The following is a description of a gene set: studied in species Homo sapiens Any of the vesicles of the constitutive secretory pathway, which carry cargo from the endoplasmic reticulum to the Golgi, between Golgi cisternae, from the Golgi to the ER (retrograde transport) or to destinations within or outside the cell. Human Gene Set: GOCC_TRANSPORT_VESICLE, and this is the list of marker genes: SYPL2, PICALM, SEC16B (SEC16 homolog B, endoplasmic reticulum export factor), HLA-DRA, ABCA12, AP1G2, ATP6V1B1, KIRREL3, DEFA4, DEFA5, SLC32A1, SNAP25, SREBF1, C1QTNF5, SLC17A8, ATM, ITPR2, PAM, SEC24A, CLTC, CPLX3, BSN, CNST, HLA-G, ATP6V1G1, NTF4, NPTX1, COPZ1, VPS45, AP1G1, PTPRN, SPX, NCSTN, OVGP1, MTMR2, APP, AP1AR, EEF1AKMT4-ECE2, NDEL1, SYT17, SEC31B (NCBI Gene Id 25956), LAPTM5, SLC9B2, CNIH2, AP1S3, STX16, SVOP, SEPTIN6, ATP6V1H, ITPR3, HLA-DPA1, UNC13B, TH, CD59, CAV2, SYN1, AP1M1, SYTL3, CA4, RAB27A, CLCN5, MYOF, STX1A, KDELR2, AP4B1 (NCBI Gene Id 10717), DRD2 (dopamine receptor D2), ATP6AP1, SYNGR2, TOR1A, SYPL1, SLC2A8, INS, FGFRL1 (NCBI Gene Id 54966), VAMP4, ATP6V0D1, FGFR3 (fibroblast growth factor receptor 3, NCBI Gene Id 55546), HLA-B, CHP1, SYT4, VAMP7, TMEM168, SLC17A6, ATP6V1F, ATP6V0C, DOC2A, ATP13A2 (NCBI Gene Id 63919), SYNGR1, ATP6V1D (NCBI Gene Id 51382), RAB11FIP5, HLA-DQB2, CHGA, VTI1B, CD74, APH1B (aph-1 homolog B, gamma-secretase subunit), GRIA1, TMED10, PSEN2, PCSK2, PDE4B, MCTP1, TMED7, SEC24D, DNM1L, CLN3, SYT5, SYNRG, TGOLN2, CLBA1, OPRK1, BACE1, SYP, ARPC2, TMED2, KIF1B, SEC16A, RAC1, SEC24B, CD55, CEACAM1, HLA-DQB1, BLOC1S5, RAB8A, FER1L5, RAB10, AP1S2, PENK, GABRA2, HLA-E, SNTB2, COPS4, SLC18A2, ARCN1, SYT6, DYSF, SYTL5, MCFD2, TGFA, SEPTIN5, PLIN3, SORT1, BLOC1S3, ATP6AP2, RAB5A, COPB1, NRSN1, SCAMP1, VAMP1, RAB3B, KLHL12, M6PR, SLC6A9, HLA-DRB3, AMPH, AREG, NRGN, SYT11, SLC6A17, SYTL4, LAMP1, PRG2, PARK7, ATP6V1G3, PSEN1, LAMP5, ARFGEF3, PEF1, WFS1, TRAPPC4, PRKN, HLA-DRB5, CIDEB, SEC23A, SLC17A9, GOPC, PDCD6, BCL2L1, KCNK9, SYT2, PPT1, COPA, RPH3A, IGF2R, VTI1A, HLA-DQA1, HLA-C, MFF (NCBI Gene Id 56947), CTTNBP2, B2M, SLC30A2, HLA-DPB1, AP1M2 (adaptor related protein complex 1 subunit mu 2), CPA3, AP3S2, RPH3AL, CLTA, ROGDI, STX17, NRSN2, HLA-DQA2, SEMA4C, RNF112, RAB5B, GOSR1, DBH, SLC30A5, RAB3C, SURF4, SYNGR3, KCNQ1 (potassium voltage-gated channel subfamily Q member 1), DISC1, TAFA4, PHAF1, HCK, SCAMP5, BET1, SYTL1, CLTCL1, RAB3A, COPG1, STON2, CNIH1, ZNRF1, AP2B1, HCRT, NCALD, TMEM187, STX10, ATP6V1C1, BDNF, STEAP2, NKD2, TMEM230 (transmembrane protein 230), TMED3 (NCBI Gene Id 23423), SNCA, MT3, BORCS5, CNIH3, SYNPR, YIPF1, ICA1, APBA1, CRYZL2P-SEC16B, OPRD1, PTPRS, SYNGR4, CDK16, FOLR1, YKT6, DTNBP1, RAB40B, COPG2, MYRIP, AP1S1, TRIM9, USO1, SLC40A1, SEC22B, ANXA13, NTF3, RAB40A, ATP6V1G2, EXOC3L1, PRRT2, ERG28, PLEKHF2, SYTL2, PICK1, DNAJC5, SNAP91, SLC30A10, AP3S1 (adaptor related protein complex 3 subunit sigma 1), AP2A1, PCSK1, SEC24C, SLC2A4, SLC17A7, VAMP2, SLC18A3, RAB9A, CACFD1, COPZ2, SLC30A8, SYT1, RABAC1, CLRN1, SSPN, SLC35F1, IQSEC1, STX5, RAB1A, GRIN2A, TRIP11, BGN, SPG21, KDELR1, YIPF3, RABEPK, SYNDIG1, UBE3A, STON1, VAMP3, HLA-DRB4, EDN1, SEC31A, SLC35D3, SCG3, BIN1, COPS5, FGFR4, SYT10, UNC13C, SYT12, RAB6A, TPRG1L, NGF, SCAP, RAB13, DGKI, SEPTIN1, SYT3, ATP6V0A1, GABBR1, GOLGA5, GOSR2, IGF1 (NCBI Gene Id 3479), RAB12, HLA-DRB1 (NCBI Gene Id 730415), HLA-F, OTOF, STXBP5, SEC13, GNAS, SYT7, APOLD1, UNC13A, RASSF9 (Ras association domain family member 9), ITPR1, IL33, SLC6A2, ANKRD27, COPB2, ATP6V1E1, COPE (COPI coat complex subunit epsilon), CRISPLD2, DEFA6, MCTP2, SV2A, TMEM163 (NCBI Gene Id 81615), SYT15, SYN2, ECE2, AZIN2, SPRR2A, ATP6V0E2, HLA-A, DPYSL3, SLC2A13, SLC30A3, RAB3D, GIPC1, MAP6, RAB27B, GPR151, CLCN4 (chloride voltage-gated channel 4), SREBF2, STX7, AP3M2, SAR1A, SLC5A7, SEPTIN8, AQP2, RAB26, SV2C, AP2M1, TMEM184A, SAR1B, PRRT1, SFTA2, STX12, CLCN3, UNC13D (unc-13 homolog D), BRSK1, BLOC1S6, ATP2B1, CLTB, SLC4A8, CALM3, SLC35G2, TMED9, SEPTIN4, MME, SNCAIP, ATP6V0A4, RAB40C, SLC18B1, BTBD8, PHF24, GOLIM4, ATP8A1, CBARP, SV2B, RAB8B, SORL1, APH1A, GRIN1, PPFIA2, SEC23IP, ATP7A, ATP6V1A, LGI3, SCGN, AP1B1, SEC23B, YIPF2, GALNT15, RAB40AL, AFTPH, ANP32E, SYN3, SLC17A5, TMEM30A, SYT8, DLG4, VMA21, SYT13, SLC18A1, KDELR3, LMAN1, VGF, RAB11A, ATP6V1B2, ABCC8, STX6, CPE, SPRED2, LRRK2, PTPRN2, NTS, RAB1B, TSNARE1, SNAPIN, HLA-H, RAB7A, HAP1, RAB11B, FURIN, RAB14 (NCBI Gene Id 51730), DMXL2, SYT9